Given this list of marker genes Adra2c, Gnb4, Gng7, Gng13, Gnb1, Gnb2, Gng12, Gng8, Gngt2, Gnb5, Gng3, Gng4, Gngt1, Gnb3, Adcy5, Gng5, Gng11, Gnai2, Gnai1, Adra2a, Gng2, Gng10, Adcy6, here is a description of the gene set: studied in species Mus musculus Adrenaline,noradrenaline inhibits insulin secretion Mouse Gene Set: REACTOME_ADRENALINE_NORADRENALINE_INHIBITS_INSULIN_SECRETION